Given this list of marker genes Hoxc13, Hdac2, Krt13, Shh, Cyp26b1, Six4, Fuz, Hdac1, Wdpcp, Intu, Ctnnb1, Six1, Tbx1, here is a description of the gene set: The process in which the anatomical structures of the tongue are generated and organized. The tongue is the movable, muscular organ on the floor of the mouth of most vertebrates, in man other mammals is the principal organ of taste, aids in the prehension of food, in swallowing, and in modifying the voice as in speech. studied in species Mus musculus Mouse Gene Set: GOBP_TONGUE_MORPHOGENESIS